The following is a description of a gene set: The somatic process allowing for the production of immune receptors whose specificity is not encoded in the germline genomic sequences. Human Gene Set: GOBP_SOMATIC_DIVERSIFICATION_OF_IMMUNE_RECEPTORS species: Homo sapiens, and this is the list of marker genes: TNFSF4, PCYT1A, CD40, NDFIP1, DCAF1, CD28, PARP3, KMT5C, PRKDC, HSPD1, ATM, PAXIP1, EXO1, LIG4, LIG1, RAG2, IL2, PTPRC, TNFSF13, TGFB1, NSD2, SHLD1 (NCBI Gene Id 149840), FOXP3 (forkhead box P3), HMCES, SWAP70, BCL6, NBN, NFKBIZ, MSH3, SANBR, STAT6, CD40LG, MSH2, HMGB1, RIF1, DCLRE1C, UNG, ADAR, NHEJ1, CTNNBL1, POLQ, CYREN, EXOSC6, BATF, POLB, ATAD5, SUPT6H, XRCC4, ERCC1, RNF8, YY1, MAD2L2, BCL11B, IL27RA, APLF, RNF168, TBX21, TFRC, SLC15A4, CCR6 (C-C motif chemokine receptor 6), KMT5B, IL4, MCM3AP, TP53BP1, SHLD2, MLH1, SAMHD1, HMGB2, CLCF1, LIG3, RAG1, MSH6, POLL, POLM, TCF3, AICDA, LEF1, PMS2, SHLD3, IL10, EXOSC3